The following is a description of a gene set: Human Gene Set: MORF_MLLT10 Neighborhood of MLLT10 Neighborhood of MLLT10 myeloid/lymphoid or mixed-lineage leukemia (trithorax homolog, Drosophila); translocated to, 10 in the MORF expression compendium species: Homo sapiens, and this is the list of marker genes: FBXL4, SYT5, IL7, ARL3, TIE1, IL4, LGI1, PCM1, POLR2K, FAM13A, TANC2, F2RL1, PDE6A, CADM4, PAX7, TBXT, NOS2, GPR171, SULT2B1, SGCD, BARX2, POU6F2, GABRB2, CDC73, RNF24, MAGEA8, DRD1, ERC1, TSSK2, MINDY2, GPATCH8, ABCC8, DNAJC16, NPFF, PDE4D, CHRNB4, CMKLR2, DDX52, TFDP2, CXCL5, BRCA1, KRT2, MFN1, KCNA5, BRWD1, MAP3K1, PRELID3A, PLPPR4, JADE3, KRR1, RAD51D, CYP2E1, ZBTB14 (zinc finger and BTB domain containing 14), TENM4, LDB3, IL13RA1, EXOC4, MAGEA9, MLLT10, GHRHR, RB1CC1, GPR18, CNTN6, USP20, AQP7, FUT1, CDYL, MYH2 (NCBI Gene Id 4620), GPR15, PPM1E, ZBTB33, HCRTR2, GPR19, RBMXL1, NOVA1, NFX1, MSL3, GUCY2F, NEB, PAX9, PSG1, ATP6V0A2, PGM3, CDH4, B3GNT3, WBP4, FGF18, ULK2, RSC1A1, USP46, AOC4P, TACC2, CYP11A1, AKAP3, FAM110B, CTRL, RYR3, LILRA1, SUPT3H, TLE1, H3C6, ATF2, MON2, CPB2 (NCBI Gene Id 81954), CYP2D6, ZNF202, COL8A1, S100A5, PIAS2, SCN7A, KDR, FAS, ARFGEF2, SPATA2, AMMECR1, GRIK5, FNTB, CLCN3, PRKCA, ADAM20, PVR, IFNA1, OR10H3, RUFY3, KRT86, SLC6A2, MASP2, TRIM24, FRY, MPZL1, AMOT, CTSB, IPO9, LINC03124, CFH, DMD, NOL4, SPA17, NPAS2, NXPE3, ZNF132, TPD52, SULT4A1 (NCBI Gene Id 25830), OCM, TNK1, ATP4B, SLC17A3, DAZL, IGKV7-3, GUCY2C, ZNF266, RORB, TTTY1 (NCBI Gene Id 50858), GCA, COL14A1, PTEN, KRT34 (NCBI Gene Id 3885), ATP10B (ATPase phospholipid transporting 10B (putative)), MYT1, PTPRB, LECT2, BMP10, SLC22A6, PPP2R5B, ERCC4, SERPINA4, SMYD3, KLRC4, COLGALT2, THPO, HNF1A, CCL16, BCL2L11, NR1I2, TMEM26 (transmembrane protein 26), ABCB1, ADAMTSL3, APOBEC1, COX6A2, STAC, KRT33A, POLR3F, ZNF141, ERC2-IT1, ZNF157, IFNW1, FLRT2, R3HCC1L, PHF10, FOSL1, NTNG2, POU6F1, BIRC5, ZSCAN26, RUNX2 (NCBI Gene Id 860), C1orf216, ZNF134, CCR3, IL16, ELOVL6, LRP4, P2RY10, DBT, PHOX2B, SIX6, OR2B6, MSH3, CD8A, FZD5, CDR1, BNIP1, PIK3CB, NR3C2, PHLDB1, COQ7, SLC33A1, CAMK4, SRPK3, ABO, ITGBL1, PSD, IFNA14, GLE1, UBE4B, CACNA2D1, IFNA10, B4GALT6, F2RL3, SLC4A8, HOXD4, COL19A1, CELA2B, DMPK, IFNA2, GLRA3, TSPAN2, LORICRIN, CRHR1, PAX6, CACNB1, HSD3B2, DNAJC22 (DnaJ heat shock protein family (Hsp40) member C22), TTN, HTR1E, ST8SIA1, POLR1HASP, SGPL1, ZBTB40, SURF2, MPP3, CALN1, SLC15A1, CEP162, ABCB10, BRD4, DGCR5, TLL1 (NCBI Gene Id 7092), ZNF33B, NFAT5, ATP8B1, MC5R, PAXIP1, SPRR2C, ITIH3, SIM2, PIK3C2A, EPHB2, MDM2, CASP10, FSHR, NRTN, EDIL3, TPD52L1, TBX19, PLEKHB1, ATXN3, SLC46A3, TMEM11, CHST1, GNG4, BRINP3, MAP2, RREB1, PART1, FGF2, GRIK1, ZP2, DRC3, GJB5, ELAVL2 (NCBI Gene Id 1993), NHEJ1, CAMTA1, JRKL, CYP4F2, CPEB3, STAG1, GCM1, RXRG, IL11RA, RPS6KA5, ADCY3, MGA